Given this list of marker genes ITGAV, TPP1, PTGER3, ITGB2, ALOX15, CIITA, ATP6V1A, NPR1, SLC1A5, DNMT1, ITGA5, SYPL1, NAGA, CD99, CDH2, RCBTB2, NAAA, DAB2, ANXA1, ITGAX, CTNND1, HLA-DRB4, NCBP2, MTMR6, CLEC10A, CCNH, QSOX1, CCR1, HLA-DMA, IGSF6, LAPTM4A, ACP5, CDH1, TOP1, CLEC2B, TGFBI (NCBI Gene Id 982), FCGRT, PRSS3, RAP1GAP, F13A1, IFI16, LST1, FGL2, MKNK1, ACTN1, DOCK1, MAF, DMPK, CCL22, PLPP3, ITGAM, HLA-DMB, SLC6A2, ADCY7, FCER2, NCF2, RAB31, ARHGDIB, P2RY6, PTPRE, AQP3, EGR2, RBMS2, here is a description of the gene set: Human Gene Set: LINDSTEDT_DENDRITIC_CELL_MATURATION_D Genes down-regulated during the course of maturation of monocyte-derived dendritic cells (DC) in response to inflammatory stimuli (cluster D). from publication Lindstedt M, Johansson-Lindbom B, Borrebaeck CA (PMID 12356685) species: Homo sapiens Maturation of dendritic cells (DC) serves a deterministic role in the link between innate and adaptive immunity, constituting a checkpoint with regard to whether responses from the lymphocyte compartment shall be raised and what class of response is needed to protect the host against invading pathogens. Since DC have not been shown to possess mechanisms such as gene recombination or somatic mutation for generating a diverse repertoire of antigen-recognition receptors, it is unlikely that these leukocytes can intrinsically respond to all conceivable molecules present in our environment. In the present study, we have therefore determined how mediators of the inflammatory response regulate global gene transcription in DC. The data represent an extensive and time-ordered reprogramming of the DC during their course of maturation, involving genes encoding proteins that regulate responses of both innate cells and lymphocytes. This transcriptional reorganization may reflect the effect of in vivo released inflammatory mediators induced by endogenous or pathogenic stimulation.